Given this list of marker genes Mtmr1, Pi4ka, Tnfaip8, Mtmr3, Pik3c2a, Pik3r2, Fig4, Mtmr6, Mtmr2, Inpp4b, Ptpn13, Inpp5j, Tnfaip8l1, Pik3cb, Pik3r5, Plekha3, Pip4k2c, Pnpla6, Pip5k1a, Arf1, Mtmr4, Rab4a, Pip5k1c, Pitpnb, Sacm1l, Tnfaip8l3, Mtmr7, Mtmr12, Plekha8 (pleckstrin homology domain containing, family A (phosphoinositide binding specific) member 8), Inpp5e, Mtmr9, Tpte, Mtmr14, Pik3c3, Inppl1, Pi4k2a, Ocrl, Synj2, Pip4p1, Pik3c2b, Sbf1, here is a description of the gene set: This event has been computationally inferred from an event that has been demonstrated in another species.<p>The inference is based on the homology mapping from PANTHER. Briefly, reactions for which all involved PhysicalEntities (in input, output and catalyst) have a mapped orthologue/paralogue (for complexes at least 75% of components must have a mapping) are inferred to the other species. Reactome Pathway: PI Metabolism electronically inferred by orthology from the curated human pathway studied in species Mus musculus part of: Phospholipid metabolism